The following is a description of a gene set: The directed movement of proteins along microtubules from the cell body toward the cell periphery in nerve cell axons. Mouse Gene Set: GOBP_ANTEROGRADE_AXONAL_PROTEIN_TRANSPORT species: Mus musculus, and this is the list of marker genes: Hspb1 (heat shock protein 1), Kif5a, Kif5c, Neto1, Kif5b (kinesin family member 5B), Rab27b, Dlg2, Mapk8ip3, Map1a